Given this list of marker genes ATP2A2, PMS1, MSH2, BTNL2, OGDH, CXCR4, FGF10, PSMB8 (proteasome 20S subunit beta 8), KRAS, IRF6, MLH1, TP63, MSH6, PIK3CA, B2M, HLA-DRB1, FGFR2, TGFBR2, TCOF1, NOD2, GRHL3, FGFR3, LYN, PMS2, EPCAM (epithelial cell adhesion molecule), SHARPIN, PLAG1, here is a description of the gene set: Human Gene Set: HP_ABNORMAL_SALIVARY_GLAND_MORPHOLOGY Any abnormality of the salivary glands, the exocrine glands that produce saliva. Abnormal salivary gland morphology species: Homo sapiens